The following is a description of a gene set: Diseases of programmed cell death Human Gene Set: REACTOME_DISEASES_OF_PROGRAMMED_CELL_DEATH studied in species Homo sapiens, and this is the list of marker genes: EZH2, LMNA, H3C10, H2BC15, DNMT1, TP53, H2BC8, H2BC12L, FOXO3, H2BC6, H2AC6, H4C15, GSDME, H4C1, H2BC13, LMNB1, H2AJ, H4C8, H3C7, H3C14, H3C1, POLA1, H2BC4, JUN, H4C16, H3C12, H4C4, H2BC21, PRDX2, RBBP4, H2BC7, TRAF2, C1QBP, H2AC4 (NCBI Gene Id 8335), H4C11, H2AB1, H2BC1, CDK5R1, CAPNS2, DNMT3A, H3C6, GOLGA2, H2AX, H4C3, CAPN2, CASP8, TRADD, H2BC14, H3C15, H4C13, H2BC9, PRIM1, H4C2 (NCBI Gene Id 8366), EED, H2AC14, SOD2, H3C3, H2BC10, CDKN2A, H2AC18, CAST, H2AC8, H4C5, FASLG, FADD, H2BC3, H2BC17, PRDX1, H3C13 (NCBI Gene Id 653604), RIPK3, RBBP7, H2BC12, H2AC7, CDC25B, CDK5, CAPNS1, H2AC19, CDC25C, MLKL, H3C2, H4C6, H3C4, YWHAE, H2AC20, RIPK1, CDC25A, SUZ12, H4C9, H2BC11, H2BC5, POLA2, H3C11, H3-3A, DNMT3B, BCL2L11, APP, H3-3B, H4C14, H2BC26, H2AZ2, H4C12, PRIM2, H3C8, CAPN1